Given this list of marker genes Aatf, Rps27rt, Tsr3, Rps3a1, Nob1, Rps25, Riok1, Dnttip2, Utp3, Rps4x (NCBI Gene Id 20102), Rps23, Wdr36 (WD repeat domain 36), Wdr3, Surf6, Nat10, Trmt112, Utp20, Utp18, Mphosph10, Mrps7, Utp23, Mcat, Rps27, Utp11, Fau, Pwp2, Rps27a, Xrcc5, Rpsa, Emg1, Ngdn (NCBI Gene Id 68966), Dimt1, Rrp7a, Bms1, Rps28, Rps15, Rps19bp1, Rps13, Exosc10, Imp3, Wdr75, Gtf2h5, Lsm6, Ddx52, Rps6-ps4, Riok2, Bysl, Nol10, Rpp40, Kri1, Rps7, Utp4, Tsr1, Rrp9, Krr1, Utp25, Mettl17, Rps11, Tsr2, Nol6, Prkdc, Rps16, Rps5, Wdr43, Nol11, Rps24, Rps9, Rps27l, Utp6, Snu13, Tbl3, Dhx37, Nom1, Riok3, Rps14, Eral1, Rcl1, Ak6, Rps21, Rps8, Rps15a (ribosomal protein S15A), Nop58, Ercc2, Utp15 (NCBI Gene Id 218488), Nop56, Ltv1, Rps12, Fcf1, mt-Rnr1, Imp4, Heatr1, Slx9, Abt1, Npm1, Rps17, Fbl, Nop14, Rrs1, Nol7, Dcaf13, Rrp36, Srfbp1 (NCBI Gene Id 67222), Rps6, 2810004N23Rik, Rps19, Nop9, Pno1, Wdr46, here is a description of the gene set: A cellular process that results in the biosynthesis of constituent macromolecules, assembly, and arrangement of constituent parts of a small ribosomal subunit; includes transport to the sites of protein synthesis. species: Mus musculus Mouse Gene Set: GOBP_RIBOSOMAL_SMALL_SUBUNIT_BIOGENESIS